The following is a description of a gene set: part of: Cytosolic sensors of pathogen-associated DNA  Innate immune responses are coordinated and regulated to provide an efficient first line of defense against pathogens and at the same time to prevent host self-damage. Here we present some regulatory events involved in the detection of cytosolic nucleic acids. Reactome Pathway: Regulation of innate immune responses to cytosolic DNA species: Homo sapiens, and this is the list of marker genes: DTX4, IRF3, RPS27A, TRIM56, NLRP4, TBK1, ZBP1, DDX41, UBB, TRIM32, TRIM21, UBC, UBA52, TREX1, STING1